The following is a description of a gene set: Advanced technology in molecular biology has provided us powerful tools for the diagnosis and treatment for cancer. We herein adopted a new methodology to identify a novel cancer/testis (CT) antigen with high frequency of expression in colorectal cancer as follows: (a) combining laser microdissection and cDNA microarray was used to analyze the gene expression profile of colorectal cancer cells; (b) genes overexpressed in testis and underexpressed in normal colon epithelium were analyzed using cDNA microarray; and (c) the gene expression profile of colorectal cancer cells was compared with that of normal testis. Using this methodology, we selected 38 candidates for CT antigen. Among these genes, we identified a novel CT antigen, serine/threonine kinase 31 (STK31), which was previously reported as a gene expressed in spermatogonia. Reverse transcription-PCR analysis showed that STK31 gene expression levels in cancer samples were significantly higher (P < 0.0001) than those in normal samples. The STK31 gene was frequently expressed not only in colorectal cancer but also in gastric and esophageal cancer. Moreover, STK31 peptide was able to elicit specific CTLs and induced CTLs lysed either peptide-loading or endogenously STK31-expressing target cells. These results showed that the new methodology in this study facilitated identification of CT antigens and that STK31 may be a candidate for cancer immunotherapy against gastrointestinal cancer. Human Gene Set: YOKOE_CANCER_TESTIS_ANTIGENS Genes up-regulated in both colorectal cancer cells and normal testis relative to normal colon epithelium. from publication Yokoe T, Tanaka F, Mimori K, Inoue H, Ohmachi T, Kusunoki M, Mori M (PMID 18281482) studied in species Homo sapiens, and this is the list of marker genes: MVK, MMP11, FABP6, CXCR2, MAGEA11, RRAD, GABBR1, TDRD9, IVD, GREB1, WFS1, NPTX2 (neuronal pentraxin 2), NUP43, SLC7A5, FAM216A, DPEP1, MPP3, STK31, LRP8, TFDP1, JADE3, CENPF, MOK, CAPN3, TUBB4A, TRIP13, LACTB2, CACNA1S (calcium voltage-gated channel subunit alpha1 S), PTGER4, OVGP1, UBE4A, MAT2A, FBXL2, ZNF200 (NCBI Gene Id 7752), PDXDC1